Given this list of marker genes Col9a1, Fnip2, Prkar2b, Ctu1, Rictor, Esr1, Tlr12, Gm20867, Mindy2, Atad3a, Prss57, Frk, Msi2, Mex3c, Fbxo46, Eri2, Dtx2, Rsbn1l (NCBI Gene Id 77477), Bzw1, P2ry4, Rnf13, Trib2, Slc2a10, Nsd2, Bap1, Spata31d1c, Chmp5, Zfp617, Cav2, Col15a1, Zc3h4, Gm20816, Fign, Itgal, Pafah1b2, Gm20806, Lrrc41, Pcbp3, Chmp6, Gm20917, Bcap29, Ssty2, Slc35f2 (NCBI Gene Id 72022), Ptbp1, Ppp1r15b, Stag1, Nipa2, Ppt1, Rtn3, Gprc5a, Dpf1, Gm20823, Tnfrsf23, Ywhag, Slc25a16, Syn1, Cers4, Gtf2a1, Hmbox1, Stxbp5, Ppp1r18, Ngly1, Gm21943, Ywhaz, Gpr3, Capza1, Plekha1, Scn4b, Dicer1, Sbk1, Rbms3, Pmp22, Rnf24, Zdhhc6, Nxph1, Mtmr3, Qrfprl (NCBI Gene Id 243407), Naip5, Dele1, Ddn, Tmem167, Prdm1 (PR domain containing 1, with ZNF domain), Tomm20, Zfp280b, Taok2, Lrfn4, 2510009E07Rik, Gm20809, Xkr8, Galnt2, Rock1, Helq, Gm20738, Ap5m1, Gm20854, Syt1, Celf1, Slc6a15, Capn8, Bach1, Adamts6, Aak1 (NCBI Gene Id 97341), Phc1, Marchf8, Rpe, Tnfrsf22, Pds5b, Fnip1, Fhit, Tspan6, Gm20747, Bloc1s5, Unc119b, Habp4, Gm20852 (predicted gene, 20852), Pdlim5, Gm20877, Grin2b (NCBI Gene Id 14812), Uggt1, here is a description of the gene set: from publication Chen Y, Wang X (PMID 31504780) Mouse Gene Set: MIR_6985_5P Genes predicted to be targets of miRBase v22 microRNA mmu_miR_6985_5p in miRDB v6.0 with MirTarget v4 prediction scores > 80 (high confidence targets). species: Mus musculus